Given this list of marker genes AGXT, CDO1, BLMH, CBS, ENSG00000274276, CSAD, MPST, FMO1, MTRR, MAT1A, TST, here is a description of the gene set: The chemical reactions and pathways resulting in the breakdown of amino acids containing sulfur, comprising cysteine, methionine and selenocysteine. Human Gene Set: GOBP_SULFUR_AMINO_ACID_CATABOLIC_PROCESS studied in species Homo sapiens